The following is a description of a gene set: Systemic inflammatory response to infection. Sepsis species: Homo sapiens Human Gene Set: HP_SEPSIS, and this is the list of marker genes: GDNF, AP1S3, CTCF, EDN3, VPS33A, SBDS, NFKB2, ATP7A, GJB2, SMO, IL2RG, HLA-B, KRT5, EFL1, ERBB2, LRBA, TFRC, EXTL3, MRTFA, SLC39A7, ABCA3, NCF1, NCF4, NRTN, FOCAD, LIG4, LAMA3, ALG1, PIK3R1, TGM1, CXCR4, CYBA, NCF2, IL36RN, ALOX12B, CD79A, FCGR3B, PEX19, ASPRV1, ELANE, ECE1, SEMA3D, SFTPB, GALM, STK4, AK2, SPINK5, SAMD9, DEPDC5, MYD88, BTK, SDR9C7, LIPN, GALT, CD79B, CD27, RAG1, AIRE, MYH11, CYBB, ACTG2, DCLRE1C, IGKC, CYBC1, COX8A, RFX5, CHD7, BLNK, IKZF1, APC, MNX1, LAMC2, IGHG2, FERMT3, SEC61A1, LAMB3, C1QB, SREBF1, SULT2B1, IGLL1, LRRC8A, CTLA4, DNAJC21, CD40LG, LMOD1, WAS, SPI1, ALOXE3, EDNRB, YARS1, RET, MYLK, FOXP3, WIPF1, SASH3, STIM1, SEMA3C, ALG12, COG4 (component of oligomeric golgi complex 4), RNF13, IL7R, ABCA12, HMOX1, MMUT, IGHM, TREX1, ADA, PGM3, ABCD1, SERAC1, NIPAL4, DOCK8 (NCBI Gene Id 81704), FOXN1, RFXANK, TCF3, RAG2, G6PC3, PKP1, RAC2, ERBB3, GJB6, SFTPC, CTNNB1, CYP4F22, HYOU1, SMARCD2, KRT14, RMRP, IDH1, DEF6